Given this list of marker genes Gzmb, Unk, Ago2, Xbp1, Dapl1, Cpeb3, Eif2a, Larp1, Rnf139, Ern1, Dapk1, Nanos1, Igfbp5, Shfl, Rpl13a, Tyms, Tob1, Cnot1, Eprs1, Cpeb4, Bc1, Tnrc6b, Pura, Lsm14a, Fmr1 (fragile X messenger ribonucleoprotein 1), Mir875, Cpeb1, Pml, Eif4ebp2 (NCBI Gene Id 69229), Enc1, Ddx3x, Rbm24, Nmnat2 (NCBI Gene Id 98444), Cnot10, Ilf3, Mir7116, Cpeb2, Ago4, Paip2, Igf2bp1, Wt1, Paip2b, Tnrc6a, Patl1, Ireb2, Rbm4, Gigyf2, Gzmc, Zar1, Eif4ebp1, Gapdh, Btg2, Qki, Mir135a-1, Mvk, Rgs2, Igf2bp2, Srp9, Trim71, Lin28a, Ago3, Fxr1, Mir448, Ncl, Wtip, Nanos3, Mir186, Limd1, Syncrip, Prkca, Habp4, D1Pas1, Serbp1, Tsc1, Samd4b, Prg3, Ajuba, Rida, Bank1, Eif4e, Cyfip1, Ybx2, Sesn2, Eif4e2, Gapdh-ps15, Eif2ak2, Ifrd2, Rack1, Alkbh3, Nanos2, Eif2ak1, Gzmn, Malsu1, Dapk3, Dap, Mir7b, Eif2s1, Gapdhrt2, Ago1, Gapdhrt, Inpp5e, Cnot9, Parp16, Ang, Pus7, Ddx6, Ang5, Zar1l, Pcif1, Dhx36, Caprin1, Mirlet7g (microRNA let7g), Mrpl13, Mir3960, Zfp598, Ybx1, Shmt1, Rps3, Zfp36, Eif4ebp3, Tpr, Wfs1, Scrib, Eif4a3l2, Mir1a-1, Eif4a3l1, Mirlet7b, Cirbp, Otud6b, Tia1, Eif4g1, Caprin2, Mir9-1, Eif6, Eif2ak3, Samd4, Map3k20, Mir143, Dnajc3, Eif4enif1, Calr, Grb7 (growth factor receptor bound protein 7), Patl2, Prkch, Xrn1, Rara, Eif4a3, Mir1247, Mir125a, Eif2ak4, here is a description of the gene set: Mouse Gene Set: GOBP_NEGATIVE_REGULATION_OF_TRANSLATION Any process that stops, prevents, or reduces the frequency, rate or extent of the chemical reactions and pathways resulting in the formation of proteins by the translation of mRNA or circRNA. studied in species Mus musculus